Given this list of marker genes Gpr17, Ltb4r1, Ltb4r2 (leukotriene B4 receptor 2), Cysltr1, Cysltr2, here is a description of the gene set: Mouse Gene Set: REACTOME_LEUKOTRIENE_RECEPTORS Leukotriene receptors species: Mus musculus